Given this list of marker genes EGF, PSMG1, SHH, RORA, FGF2, ATF5, SLC6A4, SKOR2, IGF1 (insulin like growth factor 1), CEND1, GBX2, RERE, GPR37L1, here is a description of the gene set: Human Gene Set: GOBP_CELL_PROLIFERATION_IN_HINDBRAIN The multiplication or reproduction of cells, resulting in the expansion of a cell population in the hindbrain. studied in species Homo sapiens